Given this list of marker genes STX1B, PRR14, PCNA, EIF6, LBR, SUV39H1, LMNB2, CASK, NARF (nuclear prelamin A recognition factor), FAM111B, LMNA, LMNTD2, HLCS, RNF220, LMNB1, here is a description of the gene set: Human Gene Set: GOCC_NUCLEAR_LAMINA The fibrous, electron-dense layer lying on the nucleoplasmic side of the inner membrane of a cell nucleus, composed of lamin filaments. The polypeptides of the lamina are thought to be concerned in the dissolution of the nuclear envelope and its re-formation during mitosis. The lamina is composed of lamin A and lamin C filaments cross-linked into an orthogonal lattice, which is attached via lamin B to the inner nuclear membrane through interactions with a lamin B receptor, an IFAP, in the membrane. species: Homo sapiens